The following is a description of a gene set: Human Gene Set: GOMF_OXYGEN_SENSOR_ACTIVITY studied in species Homo sapiens Binding to and responding, e.g. by conformational change, to changes in the cellular level of oxygen (O2)., and this is the list of marker genes: HIF1AN, EGLN2, NDUFS2, NOX4, PARK7